Given this list of marker genes CASP8, CCNF, BLMH (bleomycin hydrolase), MMP9, THBS2, ITGA5, MYC, HMOX1, THOP1, CTSD, SAA1, COL18A1, PERP, CYBA, KRT16, SLC26A4, JUNB, TNFRSF1A, APOC2, MMP13 (NCBI Gene Id 4322), CCL23, HSPA8, MIF, COL5A2, CDKN1A, RIN1, COL1A2, SMAD1, GLTP, MT1X, VCAM1, HSPA5, ADAM8, HLA-DQB1, SSPN, GADD45B, LGALS7, GCGR, IL4R, PYCARD, SERPINB1, SOD2, GPIHBP1, ARIH2, FOS, RCAN1, CPXM1, COL7A1, NCF2, RBMS1, MT1F, MMP14, COL1A1, BCL10, IFITM3, S100A6, TACSTD2, OSBPL1A, PRKCSH, CUL4A, APC, LCN2, UBA3 (ubiquitin like modifier activating enzyme 3), IDE, ENO1, MAOA (NCBI Gene Id 441491), PGK1, COL6A3, SOCS1, STAT3, KRT19, GABRB3, TNFRSF12A, LNX1, PLG, CRABP2, RGS2 (regulator of G protein signaling 2), RHOC, IL17RA, IL1RN, CD44, ITGB4, DOK2, ITGB1, LGALS9, CASP1, EPCAM, here is a description of the gene set: Human Gene Set: HUMMERICH_SKIN_CANCER_PROGRESSION_UP Chemically induced mouse skin carcinogenesis represents the most extensively utilized animal model to unravel the multistage nature of tumour development and to design novel therapeutic concepts of human epithelial neoplasia. We combined this tumour model with comprehensive gene expression analysis and could identify a large set of novel tumour-associated genes that have not been associated with epithelial skin cancer development yet. Expression data of selected genes were confirmed by semiquantitative and quantitative RT-PCR as well as in situ hybridization and immunofluorescence analysis on mouse tumour sections. Enhanced expression of genes identified in our screen was also demonstrated in mouse keratinocyte cell lines that form tumours in vivo. Self-organizing map clustering was performed to identify different kinetics of gene expression and coregulation during skin cancer progression. Detailed analysis of differential expressed genes according to their functional annotation confirmed the involvement of several biological processes, such as regulation of cell cycle, apoptosis, extracellular proteolysis and cell adhesion, during skin malignancy. Finally, we detected high transcript levels of ANXA1, LCN2 and S100A8 as well as reduced levels for NDR2 protein in human skin tumour specimens demonstrating that tumour-associated genes identified in the chemically induced tumour model might be of great relevance for the understanding of human epithelial malignancies as well. species: Mus musculus from publication Hummerich L, Müller R, Hess J, Kokocinski F, Hahn M, Fürstenberger G, Mauch C, Lichter P, Angel P (PMID 16247483) Selected genes up-regulated during progression through benign to malignant skin tumors formed by treatment with DMBA and TPA chemicals in the two stage skin carcinogenesis model.